The following is a description of a gene set: studied in species Homo sapiens from publication Chen Y, Wang X (PMID 31504780) Genes predicted to be targets of miRBase v22 microRNA hsa-miR-1288-3p in miRDB v6.0 with MirTarget v4 prediction scores > 80 (high confidence targets). Human Gene Set: MIR1288_3P, and this is the list of marker genes: SPRY3, ZFC3H1, FBXO11, HTR2C, POU3F3, CERS3, ARHGEF6, RBMXL1, IKZF2, RAP1A, BEAN1, DMTN, ZNF280C, ARID4A, SLC24A2, URI1, WWC1, ARL2BP, HGF, MEGF11 (NCBI Gene Id 84465), NEUROD1, ZFPM2, BRD10, SERPINB9, APPBP2, TAB3, UBFD1, EPHA7, FGF13, JCAD, PM20D2, LRCH1, SMC6, RIOK2, FOXO1, SLC2A2, HSH2D, C19orf12, STX1B, ZNRF2, MTCL2, NFKBIZ, TNPO1, GRIK2, OR51E1, TMEM196